Given this list of marker genes RFX3, ZIC1, AKIRIN1, GPR171, EPHA7, SUPT6H, DOCK8-AS1, FLRT3, TLNRD1, ZNF385B, ZNF384, NIPSNAP3B, CACNA2D2, TSC22D1, PCDH17, EXOC6, SEPTIN9, BNC2, CABP1, NFKB2, LMNA, ZNF362, KLF5, SIPA1L1, HOXD1, NR4A2, FIGN, SSBP3, RTN1, WNT6, PRDM12, PIK3R3, SLC43A2, ZNF296, LBX1, MAP2, PURG, PITX2, HOXC6, HOXD3, PLCG2, PHOX2B, ZIC4, CALCA, SCRT2, INTS8, ZNF532 (zinc finger protein 532), FES (NCBI Gene Id 2242), RNF14, P4HA1, TBX5, SLITRK2, GPM6A, IL21, RCAN1 (NCBI Gene Id 1827), CFL2, NEUROG1, ADCYAP1, TENM3-AS1, TTC12, MPP2, TLCD5, ARL4A, RHOJ, JAZF1, TMSB4XP4, ISL1, IL2, OTX2, KLHDC1, PAX2, PDE4B, FDX2, ATP5MC2, PLAGL2, PORCN, BORCS6, NEK6, SIAH3, USP13, BEGAIN, CDC42EP3, PLXNA2, SLC5A3, WNT4, ELAVL4, HMGA2, CDK14, G2E3, HOXC4, NRXN3, SAMM50, SDF2, GRHL2, HAS2, NDST4, MGAT4B, NXPH4, SLITRK5, PAN2, STAG2, CFAP69, INPP4B, TTYH1, FOXG1, PRKACB, CXCL13, XPOT, FABP1, IGFBP6, FGFR2, CCNF, HEY1, PHF21A, STAG1, GDI1, B3GLCT, H3-3B, PURA, GATA6 (NCBI Gene Id 2627), KCTD15, CEP15, RAP2A, SPMIP9, LSM12, IRX3, ZBTB37, IGF2BP3, CSMD3, HOXA5, TMSB4XP1, DMD, HEPH, SMAD4, CLVS1, GRB10, POFUT1, CACNA2D3, PTPRK, SMPX, PIPOX, NR4A3, SLC1A7, BHLHE41, CSTF3, HOXB8, LIN28A, OLIG3, LIF (LIF interleukin 6 family cytokine), ESRRG, NEUROD6, ADAM23, CNOT1, EPHB3 (EPH receptor B3), RTL10, MACC1, JPT2, IZUMO1, SLC17A6, MLLT3, SMOC1, SKIDA1 (SKI/DACH domain containing 1), JARID2, CREBZF, PTMS, TMSB4XP8, KMT2E (NCBI Gene Id 84147), KCNH7, MYO18A, CXADR, FAM117A, DLG2, SCRN1 (NCBI Gene Id 9805), KLF14, TAFA1, HS3ST4, ACACA, ZEB2, ANXA11 (annexin A11), SLAIN1 (NCBI Gene Id 122060), SRC, OLIG2, TWIST1, WDR82, DCDC1, B3GALT2, ARRDC3, PRDX5, MAP2K5, KLHL13, DCX, PCDH8, ELAVL2, SESN3 (sestrin 3), DIO2, PCDH18, SOBP, SMARCA2, MORF4, THBS2, TMEM71, BAZ2B, BMF, FBLN5, EGR2, PIM1, ATRX, PEG10, TRMT112, ADNP, RAP1GDS1, FAM50A, URM1, MRPS18B, SLC24A1, ABCC6, GPX1, ING3, RALYL, PGRMC1, HTR2C, CFAP251, GEMIN7, ZFHX4, CITED2, IRX2-DT, ANKRD28, TMSB4XP6, SEMA5B, WAPL, EBP, SLC25A3, KIF1C, TSGA13, OMD, C1orf43, RIMS1, PDE1A, NIPA2, LAMA4, IRX2, RAD18, NECAP1, TMEM255A, BTBD3, PSMB3, THAP6, GNB1L, HOXC12, PDGFA, GARRE1, MGLL, TOB1, C1orf87, PAX6, NR2E1, PPP1R10, ZBTB18, MIDEAS, NR2F2, CELF3, TMSB4X, MEIOB, SLC27A4, ZHX2, here is a description of the gene set: studied in species Homo sapiens Genes having at least one occurrence of the motif NNKGAATTAVAVTDN in the regions spanning 4 kb centered on their transcription starting sites. This matches the POU3F1 transcription factor binding site V$TST1_01 (v7.4 TRANSFAC). Human Gene Set: TST1_01